The following is a description of a gene set: species: Homo sapiens Polysplenia Polysplenia is a congenital disease manifested by multiple small accessory spleens. Human Gene Set: HP_POLYSPLENIA, and this is the list of marker genes: RSPH4A, GDF1, ODAD1, ZMYND10, DNAI1, DNAAF4, MMP21, MYCN, NPHP3, CCDC39, DNAAF11, DNAH5, FOXJ1 (forkhead box J1), RFWD3, NME8, OFD1, RPGR, WDR35, HYDIN, SPAG1, NME5, DNAH1, RSPH3, DNAL1, MCIDAS, CFAP221, CLXN, CFAP45, CCNO, GAS2L2, NEK10, CFAP74, RSPH9, DNAI2, TTC12, DRC1, CFC1, CFAP300, ZIC3, RAB23, RSPH1, YARS1, LRRC56, SPEF2, ODAD2, GPC3, DNAAF6, DNAAF2, CDON, DNAAF1, ACVR2B, CFAP298, ODAD4, CCDC40, DNAAF5, DNAH9, MEGF8, ODAD3, DNAJB13, DNAAF3, STK36, GPC4, DNAH11